Given this list of marker genes Canx, Il6st, Il27ra, Il12b, Ebi3, Il23a, Il12rb1, Tyk2, Il23r, Il27, P4hb, Jak2, Stat3, Crlf1, Il12rb2, Il12a, here is a description of the gene set: Mouse Gene Set: REACTOME_INTERLEUKIN_12_FAMILY_SIGNALING Interleukin-12 family signaling species: Mus musculus